The following is a description of a gene set: The transcription factor FoxP3 partakes dominantly in the specification and function of FoxP3+ CD4+ T regulatory cells (Tregs), but is neither strictly necessary nor sufficient to determine the characteristic Treg transcriptional signature. Computational network inference and experimental testing assessed the contribution of several other transcription factors (TFs). Enforced expression of Helios or Xbp1 elicited specific signatures, but Eos, Irf4, Satb1, Lef1 and Gata1 elicited exactly the same outcome, synergizing with FoxP3 to activate most of the Treg signature, including key TFs, and enhancing FoxP3 occupancy at its genomic targets. Conversely, the Treg signature was robust to inactivation of any single cofactor. A redundant genetic switch thus locks-in the Treg phenotype, a model which accounts for several aspects of Treg physiology, differentiation and stability. Human Gene Set: GSE40274_IRF4_VS_FOXP3_AND_IRF4_TRANSDUCED_ACTIVATED_CD4_TCELL_DN from publication Fu W, Ergun A, Lu T, Hill JA, Haxhinasto S, Fassett MS, Gazit R, Adoro S, Glimcher L, Chan S, Kastner P, Rossi D, Collins JJ, Mathis D, Benoist C (PMID 22961053) Genes down-regulated in CD4 T conv over-expressing: IRF4 versus IRF4 and FOXP3. studied in species Homo sapiens, and this is the list of marker genes: PPEF1, LAD1, GLRA3, FGF10, CNTNAP2, OGN, MUC19, HK3, GDPD4, WNT9B, LRRC37A, HEMGN, CCDC7, DUOX2, ABCA13, GNAZ, MME, PLA2G3, PLA2G5, P2RY13, IFT57, ITGB5, DAB2, ITIH2 (inter-alpha-trypsin inhibitor heavy chain 2), FBLL1, NEUROD4, MIR98, PTPRF, NEK2, MACROD2, TNFAIP2, SOCS5, GPX2, LRRC58, VWA5A, MAP3K19, IL1RN, CEBPZ, LECT2, LIPC, CCDC18, SPMAP2, HCRTR2, PLAU, BATF2, ECHDC3, RAB9B, G6PC3, LIMA1, RAB3B, SCNN1A, LRG1, TACSTD2, AMT (NCBI Gene Id 275), TNFRSF4, FGGY, SMR3A, CGA, RNF141, ARL13B, SIGLEC15, SNCG, RGN, DUSP3, CHGB, ASIC5, ID2, GATA2, MDM1, PHYHD1, CHIC1, GUCY2C, BEST2, FRMD7, LY6G5C, DOLK, ASPN, KRT86, ENAH, KCNQ3, PURG, LBP (lipopolysaccharide binding protein), CHAC1, HSF2BP, ZBED3, AURKA, DHRS7C, PPP4R1L, GABRR3, KRT77, ATF3, TRUB1, MOGAT1, SEPTIN12, LRRC19, CSPG5, SRD5A2, TMEM35A, IGFBP4, KIF24, GALNTL6, DCLK2, IFNL2, B3GALNT1, SLITRK6, CCDC38, SQOR, ITGB1BP2, OTP, CST9, MIR155, FAM161A, TIAM1, LONRF3, RUNX3, PAX2, KCNS2, CACNA1H (calcium voltage-gated channel subunit alpha1 H)